The following is a description of a gene set: Human Gene Set: GOBP_OSMOSENSORY_SIGNALING_PATHWAY The series of molecular signals initiated in response to osmotic change. species: Homo sapiens, and this is the list of marker genes: TRPV4, NLRP3, ATP1A1, PYCARD, SCN7A, CASP1, WNK3, OXSR1, TRPV3